Given this list of marker genes Coro1a, Sorl1, Rab11a, Myo1d, Rab11fip3, Dnajc13, Dync1li1, here is a description of the gene set: species: Mus musculus The directed movement of substances, in membrane-bounded vesicles, from the early sorting endosomes to the recycling endosomes. Mouse Gene Set: GOBP_EARLY_ENDOSOME_TO_RECYCLING_ENDOSOME_TRANSPORT